The following is a description of a gene set: Any process that activates or increases the frequency, rate or extent of nuclear receptor-mediated glucocorticoid signaling pathway. studied in species Mus musculus Mouse Gene Set: GOBP_POSITIVE_REGULATION_OF_NUCLEAR_RECEPTOR_MEDIATED_GLUCOCORTICOID_SIGNALING_PATHWAY, and this is the list of marker genes: Ncoa2, Ppp5c, Lmo3, Nr3c1, Ntrk2, Bdnf